Given this list of marker genes GUSB, SGSH, ARSB, HGSNAT, HYAL1, GALNS, IDUA, GLB1, GNS, IDS, NAGLU, here is a description of the gene set: studied in species Homo sapiens Human Gene Set: REACTOME_MUCOPOLYSACCHARIDOSES Mucopolysaccharidoses